Given this list of marker genes Ddx11, Dhx36, Cnbp, Nme2, Wrn, Xrn1, Blm, Pif1 (NCBI Gene Id 208084), Lonp1, Rad50, here is a description of the gene set: studied in species Mus musculus Binding to G-quadruplex DNA structures, in which groups of four guanines adopt a flat, cyclic Hoogsteen hydrogen-bonding arrangement known as a guanine tetrad. The stacking of guanine tetrads results in G-quadruplex DNA structures. G-quadruplex DNA can form under physiological conditions from some G-rich sequences, such as those found in telomeres, immunoglobulin switch regions, gene promoters, fragile X repeats, and the dimerization domain in the human immunodeficiency virus (HIV) genome. Mouse Gene Set: GOMF_G_QUADRUPLEX_DNA_BINDING